The following is a description of a gene set: Genes predicted to be targets of miRBase v22 microRNA mmu_miR_190a_5p in miRDB v6.0 with MirTarget v4 prediction scores > 80 (high confidence targets). Mouse Gene Set: MIR_190A_5P species: Mus musculus from publication Chen Y, Wang X (PMID 31504780), and this is the list of marker genes: Celf4, Prdm16, Arpc5, Mb21d2, Apcs, Casp2, B3galnt2, Mrs2, Kcnq5, Ythdf3, Tank, Chd7, Rbak (RB-associated KRAB zinc finger), Rock1, Dennd5b, Tor1aip1, Setdb2, Kcnb1, Hoxb9, Eda2r, Zfp292, Phlpp1, Trmt10a, Fgf14, Slc20a2, Trim36, Cebpa, Tcf4, Setbp1, Isoc1, Otud4, Zfp112, Nrxn1, Elavl4, Cacna1g, Zbtb41 (zinc finger and BTB domain containing 41), Trp53inp1, Eif5, Adgrb3, Lmcd1, Synj1, Dmd, Mr1, Slitrk1, Kcnmb1, Dyrk3, Pax6, Elovl5, Tdrd5 (tudor domain containing 5), Serpinb9e, Neurod1, P2ry1, Alkbh8, Gabpb2, Zfp322a, Numb, Sec14l1, Mtm1, Tnrc6b, Trnt1, Plaa, Trps1, Smpdl3b, Xpo1, Folh1, Wdr44 (WD repeat domain 44), Dynlt1a, Atf2, Cdkn1b, Pigw, Dpep1, Nlgn1, Epc2, Wsb1, Tnrc6a, Serpinb9f, Tbc1d15, Cntn3, Tbc1d14, Dag1, D630045J12Rik, Samd4, Cdin1, Myo5a, Gpr155, Gphn (gephyrin), Heca, Dop1b, Slc17a6, Kdm1b